The following is a description of a gene set: HIF-alpha (HIF1A, HIF2A (EPAS1), HIF3A) is translocated to the nucleus, possibly by two pathways: importin 4/7 and importin alpha/beta. Once in the nucleus HIF-alpha heterodimerizes with HIF-beta (ARNT) and recruits CBP and p300 to promoters of target genes. Reactome Pathway: Regulation of gene expression by Hypoxia-inducible Factor part of: Cellular response to hypoxia species: Homo sapiens, and this is the list of marker genes: EPAS1, CA9, ARNT, HIGD1A, CITED2, VEGFA, CREBBP, HIF1A, HIF3A, EPO, EP300